The following is a description of a gene set: Mouse Gene Set: GOBP_POSITIVE_REGULATION_OF_B_CELL_APOPTOTIC_PROCESS studied in species Mus musculus Any process that activates or increases the frequency, rate, or extent of B cell apoptotic process., and this is the list of marker genes: Cd24a, Fnip1, Myc, Il10, Bax